Given this list of marker genes Sinhcaf, Gm32914, Gm22792, St8sia1, Rps25-ps1 (ribosomal protein S25, pseudogene 1), Gm23462, Gm6288, Mansc4, Gm21814, Ipo8, Amn1, Gm15778, Gm10388, Gm23498, Gm6266, Etfbkmt, 1700003I16Rik, 1700034J05Rik, Gm6313, Sox5os5, Gm15786, Ints13, Gm23272, Bmal2, Dnai7, Rps4l, Etnk1, Gm15499, Sspn, Gm15762, Gm7571, Etfrf1, Mrps35, Gm15543, Bicd1, Ppfibp1, 4933406L23Rik, 4930479D17Rik, Far2 (fatty acyl CoA reductase 2), Gm7618 (NCBI Gene Id 675444), Gm35876, Far2os1, Bhlhe41, Pthlh, Gm15785, Gm15779 (predicted gene 15779), Kras, Rep15, Sox5os4, Sox5it, Gm15780, Dennd5b, Far2os2 (fatty acyl CoA reductase 2, opposite strand 2), Sox5os1, 4930579D09Rik, Gm15706, D6Ertd474e, 1700126G02Rik, 2010013B24Rik, 1700049E15Rik, Gm15707, Gm31108, Gm15783, 3010003L21Rik, 2610017A05Rik, Sox5, 4930447C11Rik, Gm15704, Gm15781, Sox5os3, Fgfr1op2, Gm15767, Tmtc1, 4732416N19Rik (RIKEN cDNA 4732416N19 gene), E330012B07Rik, Resf1, Itpr2 (inositol 1,4,5-triphosphate receptor 2), Gm25373, Gm15766, Stk38l, 1700060C16Rik, Gm6654 (predicted pseudogene 6654), Caprin2, Irag2, Gm25539, Ergic2, Gm7468, Gm15784, Gm22578, Klhl42, Smco2, 4930528G23Rik, Rassf8, C2cd5, Gm44020, 1700073E17Rik, 4930434O05Rik, Ccdc91, Sspnos, Gm15782, Tuba3b, Bcat1, Med21, Lmntd1, A930014E10Rik, Tm7sf3, here is a description of the gene set: species: Mus musculus Mouse Gene Set: chr6G3